Given this list of marker genes DDR2, MELTF, PDPN, STAT3, CARMIL2, CLASP2 (NCBI Gene Id 440948), TGFB2, FSCN1, CLASP1, IL6 (interleukin 6), MIR205, here is a description of the gene set: Any process that increases the rate, frequency or extent of extracellular matrix disassembly. Extracellular matrix disassembly is a process that results in the breakdown of the extracellular matrix. species: Homo sapiens Human Gene Set: GOBP_POSITIVE_REGULATION_OF_EXTRACELLULAR_MATRIX_DISASSEMBLY